Given this list of marker genes GFM2, NUP54, ACTB, PARK7, AOPEP, VPS16, KMT2B, FTL, here is a description of the gene set: studied in species Homo sapiens A type of dystonia (abnormally increased muscular tone causing fixed abnormal postures) that affects muscles of the legs. Leg dystonia Human Gene Set: HP_LEG_DYSTONIA